Given this list of marker genes Bok, Rnf31, Tnf, Aifm1, Cflar, Birc3, Nlrp6, Cyld, Peli1, Tlr3, Fadd, Rbck1, Map3k7, Birc2, Slc25a4, Casp8, Ybx3, Dnm1l, Itpk1, Fzd9, Spata2, Trpm7, Ppif, Mlkl, Mutyh, Fas, Ripk1, Casp6, Pygl, Ipmk, Pgam5, Ripk3, Trp53, Cav1, Zbp1, Adprs, Parp1, Fasl, here is a description of the gene set: A programmed necrotic cell death process which begins when a cell receives a signal (e.g. a ligand binding to a death receptor or to a Toll-like receptor), and proceeds through a series of biochemical events (signaling pathways), characterized by activation of receptor-interacting serine/threonine-protein kinase 1 and/or 3 (RIPK1/3, also called RIP1/3) and by critical dependence on mixed lineage kinase domain-like (MLKL), and which typically lead to common morphological features of necrotic cell death. The process ends when the cell has died. The process is divided into a signaling phase, and an execution phase, which is triggered by the former. Mouse Gene Set: GOBP_NECROPTOTIC_PROCESS species: Mus musculus